Given this list of marker genes Cmbl, P4ha1, Nrxn1, Rab30, Nfatc2ip, Arhgap42, Pon3, Plaat1, Zfp950, Baz2b, Wdr44, Taf1a, Tmod3, Pkd2, Loxhd1, Lratd1, Serpinb1a, Appl1, Cyb5rl, Sgms1, Ranbp10, Rbm47, Caln1, Spred3, Nup50, Slc8a1, Rock1, Serinc1 (serine incorporator 1), Or7e176, Kirrel1, Serpinb1c, Trps1, Tox3, Fos, Tmem41b, Taok1, Ncam2, Fgf14 (fibroblast growth factor 14), Oc90, B230219D22Rik, Adra1a, Spty2d1, Akr1e1, Rps6ka3, Zeb2, Unc80, Pcnx4 (NCBI Gene Id 67708), here is a description of the gene set: Genes predicted to be targets of miRBase v22 microRNA mmu_miR_490_5p in miRDB v6.0 with MirTarget v4 prediction scores > 80 (high confidence targets). Mouse Gene Set: MIR_490_5P species: Mus musculus from publication Chen Y, Wang X (PMID 31504780)